The following is a description of a gene set: studied in species Homo sapiens Human Gene Set: GOBP_MODULATION_BY_HOST_OF_VIRAL_RNA_GENOME_REPLICATION A process in which a host organism modulates the frequency, rate or extent of viral RNA genome replication., and this is the list of marker genes: PHB1, FBXL2, FMR1, VAPB, TMEM41B, DDX56